The following is a description of a gene set: A transcriptionally-silent heterochromatin structure present in senescent cells. Contains the condensed chromatin of one chromosome and is enriched for histone modifications. Thought to repress expression of proliferation-promoting genes. Mouse Gene Set: GOCC_SENESCENCE_ASSOCIATED_HETEROCHROMATIN_FOCUS studied in species Mus musculus, and this is the list of marker genes: Hmga2, Cdkn2a, Hmga1b, Hmga1 (high mobility group AT-hook 1), Cbx3